Given this list of marker genes Wnt3a, Cops7b, Cops7a, Cops8, Tespa1 (NCBI Gene Id 67596), here is a description of the gene set: The aggregation, arrangement and bonding together of a set of components to form a COP9 signalosome. Mouse Gene Set: GOBP_COP9_SIGNALOSOME_ASSEMBLY studied in species Mus musculus